Given this list of marker genes RAG1, SCNN1A, SCNN1G, MGAT2, MDFIC, RAG2, SCNN1B, GLI3, UNG, PIK3CD, USP9X, DCLRE1C, PIK3R1, AICDA, PTEN, ZAP70, here is a description of the gene set: Human Gene Set: HP_RECURRENT_UPPER_AND_LOWER_RESPIRATORY_TRACT_INFECTIONS studied in species Homo sapiens Increased susceptibility to upper and lower respiratory tract infections, as manifested by recurrent episodes of upper and lower respiratory tract infections. Recurrent upper and lower respiratory tract infections